The following is a description of a gene set: Human Gene Set: HP_MICRODONTIA species: Homo sapiens Microdontia Decreased size of the teeth, which can be defined as a mesiodistal tooth diameter (width) more than 2 SD below mean. Alternatively, an apparently decreased maximum width of tooth., and this is the list of marker genes: BBS4, NHP2, TRPS1, ZFX, MKKS, AXIN2, MED12, PRKACB, DPF2, SUMO1, CHSY1, IFT43, NOP10, FKBP6 (FKBP prolyl isomerase family member 6 (inactive)), TGFA, TMEM270 (NCBI Gene Id 135886), C1S, GHR, MBD5, FAM20C, CNTNAP2, BBIP1, PRIM1 (DNA primase subunit 1), CCDC47, ATP6V0A2, NECTIN1, B3GALT6, SMARCA2, SMOC2, TFAP2A (NCBI Gene Id 95131), BBS5, PAX9, PRKACA, PIGA, SNRPN, PYCR1, IFT74, TP63, VPS37D, EVC, FGFR2 (fibroblast growth factor receptor 2), SMC3, GTF2IRD2, KIAA0753, EDARADD, SIX1, METTL27, TMCO1, UBR1, KMT2D, P4HB, TCF12, ARID1B, FGF10, LTBP3, SDCCAG8, PITX2, PIK3R1, TONSL, IDUA, EDAR, BBS12, CDK13, NFIX, RHOA, TTC8, FOXC1, USH2A, FGFR3, CHST3, WNT10A, LRP6, UBE3B, EDA2R, BAZ1B, SRCAP, TWIST2, CDH3, COL3A1, B3GAT3, MAPRE2, BBS2, BBS9, GRB10, KAT6B, ADNP, WDR4, TBL2, NPHP1, ANAPC1, SCAPER, WHRN, REV3L, FGF3, ORC1, MYO7A, C1R, PCGF2 (polycomb group ring finger 2), EDA, KDM6A, GJA8, PIK3C2A, CDH11, IFT122, LIMK1, WDR19, SEC23A, NCF1, PRKD1, PDZD7, IFT52, GREM2, BBS1, CKAP2L, SLC25A24, GLI1, CEP19, FGFR1, SMARCAL1 (SWI/SNF related, matrix associated, actin dependent regulator of chromatin, subfamily a like 1), CTCF, DLX3, PCNT, RECQL4, GTF2I, CEP290, DYNC2LI1, MKS1, EVC2, RBBP8, MAPK1, ADGRV1, MLXIPL, IFT27, BBS7, EIF4H, GJA5, LZTFL1, ATP6V1B2, RMRP, CACNA1C, SATB2, DNAJC21, LMBRD2, ARL6, FBXO28, MSX1, RFC2, CLIP2, DNAJC30, IRF6, TRIM32, STX1A, GJB2, CFAP418, GJA1, BUD23, SCNM1, SCLT1, BBS10, H4C5, PLXNA1, PLXND1, MCOLN1 (NCBI Gene Id 57192, mucolipin TRP cation channel 1), PIGL (NCBI Gene Id 9487), LAMB3, BCL11B, EYA1, IFT172, IFT140, WDPCP, HS2ST1, WNT10B, WDR35, PIGF, HEPHL1, GTF2IRD1, ELN